The following is a description of a gene set: Mouse Gene Set: GOBP_REGULATION_OF_MONOATOMIC_ION_TRANSMEMBRANE_TRANSPORT species: Mus musculus Any process that modulates the frequency, rate or extent of the directed movement of ions from one side of a membrane to the other., and this is the list of marker genes: Tmc1, Scn10a, Gria1, Nlgn3, Asph, Mtor, Jph3, Gper1, Scn1b, Ppp3r1, Bpifa5, Bin1, Mettl21c, Kcns1, Plp1, Jsrp1, Snta1, Atp1b2, Nr3c2, Sestd1, Calm1, Heph, Fcrl5, Ywhae, Bdkrb1, Fgf14, Tlr9, P2rx5, Cd63, Rgs7, Atp2a1, Tesc, Grin2a, Kcnj12, Hspa2, Ngf, Tgfb2, Npsr1, Dpp10, Nol3, Grp, Gimap5, Nos1, Dysf, Edn1, Trpc6 (transient receptor potential cation channel, subfamily C, member 6), Wnk2, Ubqln1, Ppp3r2, Prkce, Lyn (NCBI Gene Id 99963), Gstm7, Slc9a1, Stimate, Mrln, Gal, Cacna1c, Ubr3, Xcl1, Grin2b, Cav1, Cemip, Pdpk1, Wnk4, Ifng, Dlg1, Gpr39, Lrrc26, Kcnj2, 1810037I17Rik, Kcnrg, Casq1, Oga, Kcnab1, Lime1, Amigo1, Pik3cg, Plcg1, Akap7, Kcnip3, Pcsk9, Coa8, Fxyd6, Stim1, Hap1, Kcnab2, Psen2, Wwp2, Atg5 (autophagy related 5), Slmap, Thy1, Gpr35, Dhrs7c, Fxyd1, Ank3, Selenon, Kcnj16, Homer1, Akt1, Kcnj5, Lrrc55, Scn4b (NCBI Gene Id 399548), Adrb2, Gsto1, Wnk3, Camk2d, Hpca, Kcnj11, Agtr1a (angiotensin II receptor, type 1a), Cx3cl1, Kcnh2, Pml, Calm3, Clec4b1, Kcnn4, Tmem38b, Vdac1, Adcyap1r1, G6pdx, Bak1, Kcnip2, Diaph1, Atp2b4, Lrrc52, Ywhaq, Ripk1, Ano6, Calm2, Atpsckmt, Kcns2, Gpd1l, Atp7a, Cacnb1, Cacnb3, Kcnj13, Slc31a2, Dmd, Gnb2, Prkd1, Cxcr3, Abcc9, Ednra, Ptpn22, Kcng4, Flna, Snca, Kcne1, Oprk1, Afg3l2 (NCBI Gene Id 69597), Kcnj10, Rnf207, Smim6, Sco1, Kcnj9, Trdn, Gjc2, Tmem38a, Ppp3cb, Asic2, Calhm1, Cftr, Cacnb4, Nppa, Prss8, Iscu, Kcnj8, Ppp3ca, Cacna1f, Fgf12, Fbxo11, Ffar1, Chd7, Ank2, Cacna2d1, Kcnab3, Actn2, Tspan13, Pln, Kcnc2, Kcnq1, Bcl2, Kcne5, Pkd2, Adrb1, Pirt, Ptger3, Scn3b, Lrrc38, Lhcgr, Aplnr, Kcnj6, Grin2d, Agrn, Scn5a, P2rx1, Atp4b, Tmc2, Wnk1, Edn3, Epo, Kel, Cxcl11, Galr2, Zfas1, Fkbp1a, Fxyd3, Tcirg1, P2ry6, Scn2b, Kcne2 (potassium voltage-gated channel, Isk-related subfamily, gene 2), Cnksr3, Cxcl9 (NCBI Gene Id 17329), Prnp, Ptpn6, Tcaf1 (TRPM8 channel-associated factor 1), Ahnak, Stac3, Fhl1, Sri, Neto1, Akap5, Gopc, Itgb3 (NCBI Gene Id 268495), Akap6, Cacng1 (NCBI Gene Id 12299), Drd4, Tmem168, Kcng3, Fmr1, Fxyd7, Casq2, Bpifa1, Kcne3, F2r, Lcn2, Kcng1, Grin2c, Cacnb2, P2rx7 (purinergic receptor P2X, ligand-gated ion channel, 7), Ppif, Sphk2, Cxcl10, Kcnj15, Tmbim6, Commd1, Pik3c2a, Cox17, Vamp2, Kcnj3, Abl1, Slc36a2, Cracr2a, Stac2, Stim2, Ucp2, Stom, Kcnmb1, Tmem74, Ywhah, Drd1, Sln (sarcolipin), Bax, F2, Taco1, Nedd4, Fyn, Kcnc1 (NCBI Gene Id 320399), Il4, Kcnj14, Ppp3cc, Fxyd5, Nherf1, Kcnj4, P2rx4, Strit1, Trpc1 (NCBI Gene Id 22063), Ryr2, Itgb1, Ntsr1, Atp4a, Cd4, Ikbkb, Akap9, Cd19, Dbi, Cacna1d, Reln, Stac, Rem1, Slc30a1, Cbarp, Il13, Grm6, Abcb1a (NCBI Gene Id 64575), Cyba, Rangrf, Stk39, Pde4d, Bmp4, Vmp1, Tgfb1, Ptk2b, Mcub, Atp1b1, Atp1a2, Fkbp1b, Hamp2, Gimap3, Phb2, Rapgef3, Plcg2, Crbn, G6pd2, Abcb1b, Osr1, Rgs4, Fxyd2, Grin1, Capn3, Chp1, Slc9a6, F2rl3, Myo5a, Ndufa4, Ms4a1, Nipsnap2, Ahr, Ctss, Kcnip4, Kcnn2, Hamp, Ubash3b, Jph2, Fgf13, Cav3, Plcb1, Drd2, Mmp9, Nherf2, Rgs9, Kcnip1, Sumo1, Hrc, Ms4a2, Slc26a5, Dpp6, Ptpn3, Slc8a1, Atp1b3, Kcnj1, Ehd3, Gnb5, Spg7, Fxyd4, Trpc3, Cacng6, Arf1, Tescl, Htt, Nedd4l, Oxsr1, Coro1a